The following is a description of a gene set: studied in species Mus musculus Mouse Gene Set: GOBP_INFLAMMATORY_RESPONSE_TO_WOUNDING The immediate defensive reaction by vertebrate tissue to injury caused by chemical or physical agents., and this is the list of marker genes: Stat3, Extl3, Alox5, Il17a, Clec10a, Mapk9 (mitogen-activated protein kinase 9), Grn, Pparg, Tlr3, Siglecg, Nfkbiz, Git1, Timp1, Hc, Cfh, Hif1a, Tnf, Il33, Tlr4, Ccr2, Hmox1, Wdr83, Reg3a, Reg3g, Dsg2, Ptpn6, F2r, Cd44, Mdk, Cd24a, Il6, Lrrc25, Il1a